The following is a description of a gene set: studied in species Homo sapiens from publication Chen Y, Wang X (PMID 31504780) Genes predicted to be targets of miRBase v22 microRNA hsa-miR-628-5p in miRDB v6.0 with MirTarget v4 prediction scores > 80 (high confidence targets). Human Gene Set: MIR628_5P, and this is the list of marker genes: BIRC6, RLF, TMEM184A, IKZF1, FAM210B, STK32B (serine/threonine kinase 32B), DCX, CAV1, ADGRE2, TRAF3, BCL6, PSTPIP2, SALL1, PITX2, PSD3, LAPTM4B, SCN3A, EMILIN3, CISD1 (CDGSH iron sulfur domain 1), LMLN, BNIP3L, HMGB3, COL4A1, SLIT2, ANK3, SMARCAD1, DMC1 (DNA meiotic recombinase 1), CHPT1, TMEM185B, NR1D2, G6PC1, ELAPOR2, SLAIN1, VASH2, LSM14A, COL19A1, CRYGN, ZSCAN31, ZBTB21, ANKRD50, NBEA, MEF2C, WDR64, TSNAX, AP4E1, ZMAT4, MRAP2, RABGEF1, GPR15, BMS1, ATP2A2, BLM, ATXN3, ACVR1, STK40, KATNAL2, SLC46A3, FUT9, KDM5B, EFR3A, NAT2 (NCBI Gene Id 10), ARHGAP36, TXNDC16, BBS1, WDFY3, CAMK4, OTULINL, EPHA3, LOXL3, ATG4A, PRTG, RORA, TMEM33, NPEPPS, ZC3H6, AHCYL2, PVRIG, PLD5, FAM168B, DEK, CCDC144NL, CHAMP1